The following is a description of a gene set: Zmpste24 (also called FACE-1) is a metalloproteinase involved in the maturation of lamin A (Lmna), an essential component of the nuclear envelope. Both Zmpste24- and Lmna-deficient mice exhibit profound nuclear architecture abnormalities and multiple histopathological defects that phenocopy an accelerated ageing process. Similarly, diverse human progeroid syndromes are caused by mutations in ZMPSTE24 or LMNA genes. To elucidate the molecular mechanisms underlying these devastating diseases, we have analysed the transcriptional alterations occurring in tissues from Zmpste24-deficient mice. We demonstrate that Zmpste24 deficiency elicits a stress signalling pathway that is evidenced by a marked upregulation of p53 target genes, and accompanied by a senescence phenotype at the cellular level and accelerated ageing at the organismal level. These phenotypes are largely rescued in Zmpste24-/-Lmna+/- mice and partially reversed in Zmpste24-/-p53-/- mice. These findings provide evidence for the existence of a checkpoint response activated by the nuclear abnormalities caused by prelamin A accumulation, and support the concept that hyperactivation of the tumour suppressor p53 may cause accelerated ageing. from publication Varela I, Cadiñanos J, Pendás AM, Gutiérrez-Fernández A, Folgueras AR, Sánchez LM, Zhou Z, Rodríguez FJ, Stewart CL, Vega JA, Tryggvason K, Freije JM, López-Otín C (PMID 16079796) Top genes up-regulated in liver tissue from mice with knockout of ZMPSTE24. species: Mus musculus Mouse Gene Set: VARELA_ZMPSTE24_TARGETS_UP, and this is the list of marker genes: Susd6, H1f2, Cirbp, Slc25a51, Myc, Mknk2, Cyp2c39 (cytochrome P450, family 2, subfamily c, polypeptide 39), Rgs16, Pim3, Csnk1d, Snhg1, Cyp26a1, Zbtb16, Gadd45b, Slc20a1, Txnip, Btg3, Adarb1, 1700017B05Rik, Btg2, Snhg6, Nr1d1, Cdkn1a, Lepr, Zfp36l2, Tiprl, Mapkapk2, Bcl2l1 (NCBI Gene Id 12048), Erf, Atf4, Ncdn, Baiap2, Sesn1, Gadd45g (NCBI Gene Id 97898), Cux2, Atf3, Gadd45a, Tsr1, Klf3, Pi4k2a, Cd14, Ddit4, Tnfrsf1b, Crcp